Given this list of marker genes ACTR2, ORC4, WASHC5, SHCBP1L, ACTR3, SPIRE2, FMN2, SPIRE1, here is a description of the gene set: A cell cycle process that results in the division of the cytoplasm of a cell after meiosis, resulting in the separation of the original cell into two daughter cells. Human Gene Set: GOBP_MEIOTIC_CYTOKINESIS species: Homo sapiens